Given this list of marker genes CIB1, SLC24A5, FANCB (NCBI Gene Id 2187), MKRN3, UBE2A, EDNRB, HLA-DRB1, SNORD116-1, SLC45A2, SMO, SDHC, PORCN, TINF2, BLOC1S3, HRAS, MITF, FANCG, CTNS, WDR73, SLC35A2, UBE3A, SEC24C, PTEN, PPOX, BLOC1S6, ACP5, CTC1, RAF1, ANAPC1, POLH, DKC1, SMS (spermine synthase), PAH, GP1BB, SNORD115-1, WRAP53, CD28, ZNF699, BTK, BRIP1, HPS5, FANCC, TERT, CTSC, SLC6A19, UBE2T, LRMDA, APOE, TOE1, COMT, USB1, RECQL4, CAV1, SDHB, MAFB, SKIC3 (NCBI Gene Id 9652), AKT1, GALC, BRCA1, PWRN1, EDN3, PAX3, GATA1, LAMTOR2, ZEB2, XRCC2, PARN, EPG5, CRIPT, SOX10, ZPR1, CHN1, FAS, KRT14, MAD2L2, SLX4, FGFR3, NOP10, TWIST2, HCCS, FERMT1, HIRA, IL7, OCRL, TMC8 (NCBI Gene Id 147138), KRAS, IFNG, FANCL, ABCC9, PTPN22, RREB1, KLLN, RTEL1, JMJD1C, SASH1, TYR, NRAS, ATP7A, OCA2, FANCA, BLM, PCSK1, CBS, PSENEN, XPA, FANCM, ARVCF, WDR45, APC2, HPS1, FANCF, HPS4, COX7B, CCR6, FANCI, TNFRSF1B, NSD1, NDUFB11, USF3, KITLG (NCBI Gene Id 780897), SIM1, CLCN7 (NCBI Gene Id 7814), MLPH, TSC1, AP3B1, KRT5, KIAA0319L, PWAR1, UFD1, PIGN, BLOC1S5, UROD, NHP2, SEC23B, MC1R, PSAP, CTLA4, TBX1, DCPS, PIK3CA, ERF, NDN, KIT, TYRP1, FANCD2 (FA complementation group D2), BRAF, NPAP1, CCN2, EBP, TMC6, MTOR, SLC17A5, DPP9, SOX5, ADAR, RFWD3, AIRE, ALG3, CLTRN, DCT, KLHL24 (NCBI Gene Id 79965), SPTBN1, PALB2, FGFR2 (NCBI Gene Id 2263), TP63, DTNBP1, TFE3, NPM1, MLH1, RAD51C, POMC, POFUT1 (NCBI Gene Id 23509), FANCE, MYO5A, TCF4, TYMS, LYST, BTNL2, ERCC2, LIPE, BRCA2, IKBKG, RAB27A, DDB2, HERC2, ERCC5, HPS3, ATP10A, SNAI2, ZFX, WDR11, POGLUT1, RAD51, TSC2, LMNA, ERCC4, HPS6 (HPS6 biogenesis of lysosomal organelles complex 2 subunit 3), SDHD, ABCB6, SNRPN, DNAJC21, AP3D1, MAGEL2, ALK (ALK receptor tyrosine kinase), XPC, SALL4, TERC, UROS, GNPTAB, ERCC3, IRF5, ANTXR1, KANSL1, SKIC2, PCNT, here is a description of the gene set: A reduction of skin color related to a decrease in melanin production and deposition. Hypopigmentation of the skin species: Homo sapiens Human Gene Set: HP_HYPOPIGMENTATION_OF_THE_SKIN